Given this list of marker genes CLDN4, PRB2, IFI27, ZFP36, H2AC8, H2AC20, PI3, IL18, JUND, BAMBI, IL1RL1 (interleukin 1 receptor like 1, NCBI Gene Id 9173), NEFM, TM4SF1, TSC22D1, BCL6, FLG, HBP1, SULT2B1, S100A9 (S100 calcium binding protein A9), H2AC18, ECM1, PDLIM4, TUBB2A, PRSS3, here is a description of the gene set: Cluster G24: genes induced in NHEK (normal keratinocyte) but not in SCC12B2 cells (squamous cell carcinoma) by UV-B radiation. Human Gene Set: DAZARD_UV_RESPONSE_CLUSTER_G24 To gain insight into the transformation of epidermal cells into squamous carcinoma cells (SCC), we compared the response to ultraviolet B radiation (UVB) of normal human epidermal keratinocytes (NHEK) versus their transformed counterpart, SCC, using biological and molecular profiling. DNA microarray analyses (Affymetrix), approximately genes) indicated that the major group of upregulated genes in keratinocytes fall into three categories: (i). antiapoptotic and cell survival factors, including chemokines of the CXC/CC subfamilies (e.g. IL-8, GRO-1, -2, -3, SCYA20), growth factors (e.g. HB-EGF, CTGF, INSL-4), and proinflammatory mediators (e.g. COX-2, S100A9), (ii). DNA repair-related genes (e.g. GADD45, ERCC, BTG-1, Histones), and (iii). ECM proteases (MMP-1, -10). The major downregulated genes are DeltaNp63 and PUMILIO, two potential markers for the maintenance of keratinocyte stem cells. NHEK were found to be more resistant than SCC to UVB-induced apoptosis and this resistance was mainly because of the protection from cell death by secreted survival factors, since it can be transferred from NHEK to SCC cultures by the conditioned medium. Whereas the response of keratinocytes to UVB involved regulation of key checkpoint genes (p53, MDM2, p21(Cip1), DeltaNp63), as well as antiapoptotic and DNA repair-related genes - no or little regulation of these genes was observed in SCC. The effect of UVB on NHEK and SCC resulted in upregulation of 251 and genes, respectively, and downregulation of genes in NHEK and genes in SCC. To further analyse these changes, we used a novel unsupervised coupled two-way clustering method that allowed the identification of groups of genes that clearly partitioned keratinocytes from SCC, including a group of genes whose constitutive expression levels were similar before UVB. This allowed the identification of discriminating genes not otherwise revealed by simple static comparison in the absence of UVB irradiation. The implication of the changes in gene profile in keratinocytes for epithelial cancer is discussed. studied in species Homo sapiens from publication Dazard JE, Gal H, Amariglio N, Rechavi G, Domany E, Givol D (PMID 12771951)